The following is a description of a gene set: from publication Yamagata T, Benoist C, Mathis D (PMID 16623764) Three innate (B1-B, NKT, CD8aaT cells) and adaptive (B2-B, CD4T, CD8abT cells) cell-types were sorted by FACS. Three biological replicates for NKT, CD4T, CD8aaT, CD8abT cells and two biological replicates for B1 and B2 cells were generated and the expression profiles were determined using Affymetrix Mu74Av2 chip. Comparisons between the sample groups allow the identification of genes differentially expressed between the innate and adaptive cell-types. Human Gene Set: GSE3039_NKT_CELL_VS_B1_BCELL_UP studied in species Homo sapiens Genes up-regulated in NKT cells versus B1 B lymphocytes., and this is the list of marker genes: CKLF, SORBS1, SLC4A1AP, MAPK13, BLTP1, HSD17B1, KCNN3, DENND1C, ARHGAP45, RNF24, PAXX, OLFML2B, DNAH9, BET1L, TMEM234, C1GALT1C1, MFSD4B, SVIP, FGL2, EP300, MAPK4, GGT5, DLL3, CA5A, TRADD, TRMT9B, ATP1A2, CMIP, E2F4, SLC25A20, VRK1, OGFRL1, NCAM1, SP4, RP1, TMCO6, TUBA4A, CDC42EP3, GPN2, PQBP1, SLC2A4RG, ITGA5, CANT1, KCTD11, ZNF212, SLC38A2, INTS6L, ZRANB1, ARAP1, SNX11, MED11, HNRNPUL1, GPSM3, SLC6A13, SLC37A1, SAA1, PHRF1, LYPLA2, TMUB2, C1orf56 (NCBI Gene Id 54964), IFNLR1, CCDC97, PBXIP1, TMEM213, LBH, AP1S2, ZNF76, JAK2, H1-4, PRAM1, KCNJ11, ECEL1, SUDS3 (NCBI Gene Id 64426), CCM2, TSPAN10, GPR146, ACIN1, VCAN, FGF20, ATXN7L1, OPRL1, ZNF808, KRT34, GPR27, ZNF473, LFNG, CTDSP1, YPEL5, ABCA13, IL18R1, MYF6, SERPINA11, KIAA2013, TBKBP1, CRTAM, ATP6V0A1, ZNF646 (zinc finger protein 646), RIPOR2, CYTIP, DLGAP2, PLD1, MARK2, ATP2A3, IGSF9B, MMP7, DUSP16, SIPA1L3, CCND3, ACAT2, SLC27A2, BMP8A, PDZD11, KLF13, PAGR1, FHIP2B, PTCD1, SLFN12L, USF1, CBX7, SYS1, BMP8B, SLC66A2, S100A13, GPBP1L1, LAMTOR4, SMIM23, TENM1, PRELID3A, EZH1, S100A6, INPP5A, TFEB, KMT2D, MINDY1, SLC6A4, OLFM4, ID1, ATF5, RCSD1, LEMD2, RASSF2, STK38, OGA, CNOT3, TFEC, GATA4, ARPP19, RASSF3, SOBP, HDAC7, ZNRF1, CCNO, S100A8, MYCN, LRG1, ERICH3, CDIPTOSP, NYX, WDFY4, UBP1, CKAP4, WDR83OS (NCBI Gene Id 51398), EED, ZNHIT1, TBX6, MON1A, ITPRIP, EFNB3, TXNL4B, PDE4A, CORO2A, ZSWIM8, WDTC1, SMIM12, CEBPD, RASGRP4, TSC22D4, SLU7, BAZ2B, YWHAH, PDE1B, B3GNT8, AOPEP, DDI1, ABTB2, IP6K1, BZW2, BIN3, MLXIP, TRIM34, LTB, SLCO4A1, FIS1, SAMD9L, VAMP1, ADAM28, RTN3, SEMA4B, ADAM19